Given this list of marker genes XRCC6 (X-ray repair cross complementing 6), XRCC4, PSIP1, XRCC5, BANF1, HMGA1, LIG4, here is a description of the gene set: 2-LTR circle formation studied in species Homo sapiens Human Gene Set: REACTOME_2_LTR_CIRCLE_FORMATION